Given this list of marker genes RPL23, CP, MYL1, SF3B2, CAPZB, ZNF445, SLC48A1, ERC1, CCDC71, FADS2, KDM8, ZMYND11, DPYSL3, CENPV, TSHR, GHR, ELOVL3, RAMP2, LGALS9, KLF3, MGA, FBLN2, MSH4, INTS12, CLCF1, GIP, PNPLA2, ITIH5, SLC39A3, RXRA, LASP1, BMP1, EXTL3, HOPX, GABRP, COL4A5, RTP4, TENM4, DRAM1, MR1, SEC61A2, JAK1, UCP3, UBL5, LUM, WDR48, APBA3, SORBS1, UBE2H, NCOA4, RARRES2, CHD4, PLIN4, CFAP97, RBFOX2, NCF2, IL36A, AK3, WWC1, FGFR2, S100A10, SPRR1B, DRAM2, POLR3A, CPT1B, ANGPTL2, APOA4, CLNS1A (NCBI Gene Id 1207), CCT2, PCOLCE, EPHX1, PPP3CA, IAPP, CEACAM1, CCNL2, SERPINA12, SCUBE1, FABP4, CEBPG, CASQ1, CAP1, TMEM131L, BZW1, RAB31, SHMT1, KRT85, ASB7, RASL11B, OVOL1, TMCC3, DMD, RABGAP1, TNFSF14, CRYL1, GNAS, PC, C4orf3, ST3GAL2, HHIP, GSK3B, PIGB, HJURP, FRYL, CTSB, THRAP3, PBK, SGCG, SLC22A5, RNF14, GOLGA4, KIF20A, SPRR2D, TSLP, RBBP4 (NCBI Gene Id 91125), LMTK2, EFNB1 (NCBI Gene Id 1947), CLDN11, RBMS1, HMGCS2, SERPINF1, CFD, LCP1, DGCR2, PHB2, ACTN3, IMMT, KRT77, TPR, RARG, IDE, CAMK2B, ZDHHC5, NABP1, SRRM1, SREK1, BID, LAPTM4A, SERPINB2, KRT17, KRAS, CYP4B1, PTPRF, IP6K1, RYR1, FHL2, TCF12, CTDSP2, NUBP1, SOX9, ABCA2, TMOD2, ITGAV, AIF1L, WNT5A, OS9, UBQLN4, SHISA2, PTGS2, CES4A, BACH1, PABPN1, EGFR, CALD1, FBLN1, PRMT5, TUBGCP2, NCF1, HLA-DQA2, LIMS1, MYH1, FTH1, SPAG5, TNFRSF19, GLO1, CA4, FGL2, TCF7, OSR2, FUT2, BABAM2, CMTR1, KRT16, MTF2, CHD9, SMAD1, RIOK3, SLC39A11, KRT12, PLA2G2F (NCBI Gene Id 64600), PCSK6, PLCB1, FOXP1, ADD3, INCENP, PON3, PUM1, SNX30, ABCE1, ART3, SPRR1A, SLC35A2, PDAP1, TRBV28, CKM (NCBI Gene Id 95741), CAV2, ACOX1, CASP6, GDPD3, CEP85, SLC35A3, C1D, ERO1A, ART1, ACTA1, NDUFA2, CUX1, PFKFB3, TMEM106B (transmembrane protein 106B), SEPTIN8, CCNL1, CD74, ANK3, GJA1, APP, TCAP, RMND5B, HOXB2, TP63, MRPL39, PKIG, ZNF148, HOXB6, DCUN1D1, HMGB1, CAPRIN1, CAV3, MIR214, SIRPA, IFI27L2, RAB6A (NCBI Gene Id 5870), ACTB (actin beta), USP18, CA13, THBS1, CCL20, CENPB (centromere protein B), WEE1, NDUFAF7, CLCA3P (chloride channel accessory 3, pseudogene), CTBS (chitobiase), KRTDAP, TRIP13, CAT, RFC1, SLC25A13, SERINC3, CHPT1, BNIP3, LILRB1, BCL2L13, PJA1, XDH (xanthine dehydrogenase), HCAR2, CFL2, TGFBR3, COL1A1, RRAD, STAR, HACD2, AURKC, ARPP19, ELOVL6 (NCBI Gene Id 79071), PKDREJ, CHRND, DDX3X, CARS1, MCM6, CELF2, SNCA, PRELP, FABP1, ASPH, AVPR1A, EMP2, CD59, DNAJC3, AKR1B10, WASHC2C, ADGRG1, DNPH1, LTC4S, RDH11, PCK1, SDCBP2, NME7, TF, BAALC, AGPAT1, JUNB, CRIM1, PTPRE, MGLL, PITPNB, MSRA, CCND1, KRTCAP2, NHSL1, RPTN, IL6ST, CRYBA4, TWSG1, QSOX1, TCF20, ACTRT2, MAP3K5, GPD1 (NCBI Gene Id 2819), NLK, RHOV, ATP2A1, FECH, NDUFA3, HMGA1, LPIN1, RGS4, DUSP1, YPEL1 (NCBI Gene Id 94021), GJB6, PGD, ARL5A, IKZF1, TIMP1, LIPE, MRC2, MT1F, CD44, CDKN1A, STARD4, PDPK1, PMFBP1 (NCBI Gene Id 83449), HMGA2, TGFBR2, SPIN1, ZFR, PLK1, G6PD, XRN2, PRMT6, EIF4G1, CX3CR1, HBS1L, PPP4R3B, STRBP, CPD, BRAT1, DLX1, ILF3, HSPB7, NDUFA5, MST1R, DNAJC17, FUCA1, RRM1, AATF, AMMECR1L, TPO, KRT75 (NCBI Gene Id 9119), CACNA2D1, NAV2, PDE3A, ZNF574, ATXN7L3B, SULT2B1 (NCBI Gene Id 6820), ETHE1, PINK1, SPESP1, ACSL1, LGALS1, AGK, HSPA9, POU2F3, GSTZ1, XIST, NR3C1, SNRPG, MIF4GD, LGR5, SMARCA4, RIOK2, TCEA1, BACH2, EML5, RECQL, UCK1, CLDN15, WDR12, HLA-B, DYNLT1, PDK4, LMNB1, GCLC, ATM, RCC2, DNAJB1, TCEAL3, TMEM45A, TIMP3, RTN4, ZFP36, KRT36, ACO1, NCAPD2, HCFC1, ERI2, PRKAR1B, EPHA5, VAMP8, PDLIM5, CCND2, SCD, TSPO, FSCN1, PRKACB, UCP2, HBP1, SLC25A48, ITGA9, LDHC, SPON1, MAN2B1, CIDEC, TXNIP, RBM6, FOXC1, LRG1, ADD1, FRMD4B, ZNF106, PMEL, WARS1, PURB, ELOC, PSAP, ZNF260, PLD1, SAR1A, PDS5A, NTN1, QNG1, MRPL3 (mitochondrial ribosomal protein L3), RNF114, HNF4G, ABCB8, ACSL5, FGFBP1, SIGMAR1, TMEM234, BCAP31, MAP1B, RETNLB, ITM2A, HOXA9, CLDN10, INPPL1, SOD3, UBLCP1, IL36RN, SWSAP1, WDR45, MYO5B, NKD2, FGF7, CENPA (centromere protein A), ESYT3, LANCL2, NAP1L1, UBC, TG, CHCHD10, SH3KBP1, MGAT2, IL36G, SREK1IP1, IER3, SKP2, RPL3L, HACD3, IL1R2, MAN1A2, THRSP, FAH, CLCN3, YKT6, SAP18, AMD1 (NCBI Gene Id 262), TCIM, RGCC, CAPN6, PRPS1, RANBP9, CER1, PCCA, LGALS3BP, C1orf54, MIS12, NR4A1 (NCBI Gene Id 93352), USP34 (ubiquitin specific peptidase 34), ARCN1, HIF3A, GZMH, LYZ, TP53, SUCO (NCBI Gene Id 51430), LSM12, ADIPOQ, ATPAF2 (ATP synthase mitochondrial F1 complex assembly factor 2), LGALS7, PIWIL2, TAOK1, CLK1, GOSR2, ACAA2, SERP1, MOB1A, SOX5, USF1, KAT7, SPTBN1, CTR9, PTPRG, PCYT1A, HDLBP, NT5E, PTBP3, RBBP6, MISP, QKI, SRPK1 (NCBI Gene Id 6732), OPA1, AP3M1, UBE2D3, EPHX2, SLC25A30, TPSD1, YIPF4, NSUN4, PSME4, NEUROD4, TFRC, NEDD4 (NCBI Gene Id 4734), SLC2A4, SCAF11, FBP2, NEU2, SCOC, CCL15, AQP1, SAFB2, PTPN13, WRN, UQCRB, RPN2, DNM2, KLB, MEF2A, TFDP1, CDH3, LRRC8C, HADH, IGF2, SLC11A2, RAD21, RASSF3, NIT2, CLDN5, PEG3, SLC5A6, ATF2, NSF, TM6SF2, STX18, CYSRT1, RBP7, RETN, LPL (NCBI Gene Id 4023), FKBPL, PRKD3, SIAH1, HERC6, PAPOLA, SMAD5, CERS4, SOX4 (NCBI Gene Id 6659), IL2RG, GLRX, STOM, MYH6, FAM107B, CDC42BPA, SLC25A10, APOC2, PEX13, CCN1 (NCBI Gene Id 3491), C1QB, LY6D, DDR1, GBP2 (guanylate binding protein 2), COA5, GRB10, LEP, KIF11, MRAP, PLEC, CAMKK2 (NCBI Gene Id 121657), PECAM1, RHOG, BAD, CAB39L, RACGAP1, TGS1, GNA12, MKI67, CYP17A1, IDH3G, EIF4H, ALAS1, SH3RF1, APLP2, TREX2, GPSM1, RAB40C, RPA1, CAMK4, TBRG4, EIF4EBP1, LMAN1, EIF3A, RAB12, SF3A2, HR, RNF41, SNRPN, PTPN14, GET3, CD36 (CD36 molecule (CD36 blood group)), ERRFI1, ACBD3, KRT79, AP4S1, COL6A2, TECR, ROPN1L, MAP2, CTNS, HIPK3, PDE4DIP, GRK4 (NCBI Gene Id 2868), CALHM5, BRD2, ARHGAP1, TPP2, CA3, RAB2B, MASP1, SGPL1, ZC3H11A, ABCC5, PMEPA1, PLEK2, ETFDH, FADS3, HIPK2 (NCBI Gene Id 653052), UBAP2L, CWH43, GGT1, BTC, BMERB1, ENC1, EREG, PTGFR, MFAP5, NNAT, GNA13, MT1X, DLX3, SNCG (NCBI Gene Id 6623), here is a description of the gene set: from publication Martínez-Cruz AB, Santos M, Lara MF, Segrelles C, Ruiz S, Moral M, Lorz C, García-Escudero R, Paramio JM (PMID 18245467) Genes up-regulated in mice with skin specific knockout of RB1 by Cre-lox. studied in species Mus musculus Squamous cell carcinomas (SCC) represent the most aggressive type of nonmelanoma skin cancer. Although little is known about the causal alterations of SCCs, in organ-transplanted patients the E7 and E6 oncogenes of human papillomavirus, targeting the p53- and pRb-dependent pathways, have been widely involved. Here, we report the functional consequences of the simultaneous elimination of Trp53 and retinoblastoma (Rb) genes in epidermis using Cre-loxP system. Loss of p53, but not pRb, produces spontaneous tumor development, indicating that p53 is the predominant tumor suppressor acting in mouse epidermis. Although the simultaneous inactivation of pRb and p53 does not aggravate the phenotype observed in Rb-deficient epidermis in terms of proliferation and/or differentiation, spontaneous SCC development is severely accelerated in doubly deficient mice. The tumors are aggressive and undifferentiated and display a hair follicle origin. Detailed analysis indicates that the acceleration is mediated by premature activation of the epidermal growth factor receptor/Akt pathway, resulting in increased proliferation in normal and dysplastic hair follicles and augmented tumor angiogenesis. The molecular characteristics of this model provide valuable tools to understand epidermal tumor formation and may ultimately contribute to the development of therapies for the treatment of aggressive squamous cancer. Human Gene Set: MARTINEZ_RB1_TARGETS_UP